The following is a description of a gene set: Genes up-regulated in bone marrow-derived macrophages: untreated versus stimulated by IFNG. from publication Liu SY, Sanchez DJ, Aliyari R, Lu S, Cheng G (PMID 22371602) studied in species Homo sapiens We used microarrays to compare interferon-alpha (IFNa)- and interferon-gamma (IFNg)-stimulated genes under an equivalent biological input. The goal was to compare IFNa- and IFNg-stimulated genes, as well as to identify common and distinct sets of type I and II ISGs. Human Gene Set: GSE35825_UNTREATED_VS_IFNG_STIM_MACROPHAGE_UP, and this is the list of marker genes: KALRN, ACTN1, CFLAR, IRF9, IFT57, PLEK, RTP4 (NCBI Gene Id 64108), PLLP, CCNG2, SLC7A2, RBPJ, RASGEF1B, P4HA1, CHAC1, CLN5 (CLN5 intracellular trafficking protein), PML, GPR183, DENND5A, ACP5, DMKN (dermokine), SPRYD7 (SPRY domain containing 7), CD47, UBE2E3, CASP4 (NCBI Gene Id 837), ZSWIM4, GSR, SYK, RAI14, PTGS2, MTMR12, ADM, PLA1A, BCL3 (NCBI Gene Id 602), ZCCHC2, FRMD6, HILPDA, TNFSF9, COL27A1, TRAF5, ZNFX1, GDF15, TRIM21, CAV1, SPTLC3, IGSF6, CLIC4, PROCR, SERPINB2, TMEM178A, LAD1, CCL24, PARP9, CSF3, AGPAT4, SAA1, TRIM5, OSGIN2, FGD5, TENT2, IRF7 (interferon regulatory factor 7), MLLT6, PCYT1A, PNRC1, CDK17, AVPI1, STAT4 (NCBI Gene Id 6775), STAP1, IFRD1, PLPP3, CLEC6A, RASSF8, FABP3, MALT1, ITGA5, DYRK2, TMEM39A, PTPN12, MAP4, DLG5, FILIP1L, VCAM1, TMA16, ABCC5, CYBB, NKX1-2 (NK1 homeobox 2), SLC2A1, AARS1, HP, JARID2, PCNX1, HSPA1B, CD83, HK2, TUBB6, CDKN1A, NFKBIE, BCL2L14, CD70, BIRC3, NFKBIA, EHD3, AMPD3, ID2, RHBDF2, TOR3A, SLAMF7, OGFR, ESD (esterase D), CD200, SLC11A2, VAV3 (vav guanine nucleotide exchange factor 3), IL1A (NCBI Gene Id 3552), CCDC88A, PLEKHF1, STX11, HMGCS1, PTPRJ, PRDX6, GRAMD2B, HCAR2, FOXP4 (NCBI Gene Id 116113), SAMSN1, TIMP3, MMP14, ZMIZ2, GBP6, STAT1, ITGA2B, TOR1AIP2, VCL, HBEGF, BCL2A1, USP54, NR4A3, IFIT3, MREG, IFNG, PIK3R5, SLC2A6, TJP2, PTPN2, ADAR, SLC7A11, GTPBP1, KIAA0040, CSNK1E, RCAN1, MESP1, PTGES, KIF3C, RILPL2, CMTR1, MCOLN2, CHI3L1, AGRN, GRHL1, BATF2, C3, HLA-B, RNF19B, HSH2D, PTPN23, SLFN5, SEMA7A, NLRC5 (NLR family CARD domain containing 5), TPI1, PSME2, PGPEP1, ZNF131, NOCT, JAG1, RELB, GCH1, IRAK3, KPNA3, PDPN, LPIN2, RAB22A, RASA2, MAP3K8, GBP4, GNA13, B4GALT5, TMEM151B, IL2, EBI3, RC3H1, URM1, SLC16A3, ZC3HAV1, IL1RN, MARCHF5, SH3BP2, OCSTAMP, SYNPO2, MED13L, RHOF (NCBI Gene Id 54509), PEDS1, STK40, DUSP5